The following is a description of a gene set: studied in species Homo sapiens Pathway Definition from KEGG: G00157 -- EXTL2/3 >> EXT1/2 >> EXTL1/3 >> NDST >> GLCE >> HS6ST1 -> Heparan_sulfate Human Gene Set: KEGG_MEDICUS_REFERENCE_HEPARAN_SULFATE_BIOSYNTHESIS Heparan sulfate biosynthesis. Pathway ID: N01582. Pathway type: Reference. Pathway class: nt06029 Glycosaminoglycan biosynthesis., and this is the list of marker genes: EXTL3, GLCE, EXT2, EXTL1, HS6ST1, NDST1, EXT1, NDST3, NDST2, NDST4, EXTL2